Given this list of marker genes DYNC2I2 (NCBI Gene Id 89891), DYNC2LI1, DYNC1LI2, DNAI1, TRIM58, DNALI1, DNAI4, DYNC1LI1, DYNC1I2, DNAI2, DYNC1I1 (dynein cytoplasmic 1 intermediate chain 1), DNAL1, LRRC61, DYNC2I1, DNAI3, here is a description of the gene set: species: Homo sapiens Human Gene Set: GOMF_DYNEIN_HEAVY_CHAIN_BINDING Binding to a heavy chain of the dynein complex.